The following is a description of a gene set: An abnormality of the external nose. Abnormal external nose morphology Human Gene Set: HP_ABNORMAL_EXTERNAL_NOSE_MORPHOLOGY studied in species Homo sapiens, and this is the list of marker genes: BCR, FLNB, FRMPD4, HDAC4, EFEMP2, MARS2, CDK10, OFD1, LRP4, EDAR, PTPRF, ZIC2, HUWE1, PEPD, RAP1GDS1, H3-3A, CHST14, PRKCZ, PUS1, PACS1, EDARADD, PHGDH, COL3A1, CHD5, GLB1, ALG3, SKIC3, BICRA, NFIX, ASXL1, ABCA12, TRIO, IFT122, ADAMTS18, COG1, CILK1, ANKRD11, PLAAT3, RAC1, ZNF699, TMEM107, ADGRG6, BRF1, TP63 (NCBI Gene Id 8860), PNKP, RHOBTB2, NSD2, WWOX, UFC1, ZPR1, PIGL, ALDH18A1, SRD5A3 (NCBI Gene Id 79644), INPP5E, AP4B1, RALGAPA1, SHANK3, ALDH1A2, DIS3L2, ATP6V1A, GJA1, SALL4, SPTBN1, EYA1 (NCBI Gene Id 2138), GLI3, CRIPTO, PEX11B, HS2ST1, JMJD1C, PDHA1, POU1F1, PTF1A, FZD2, ATP7A (NCBI Gene Id 613259), NALCN, SPEN (NCBI Gene Id 348488), PIGY, TEFM, AGA, H4C3, PGAP2, KCNJ11, NUP85, NODAL, COG8, TXNL4A, DNMT3B, PKHD1, EIF5A, LTBP3, ADAR, SMARCAL1, KDM6A, H4C5, JARID2, TBCE, CUL7, SETBP1, SNX14, CERT1, CAPN15, SYT1, AMMECR1, FOCAD, CHD6, PDE4D, COL27A1, PEX5, STAG2, RALA (NCBI Gene Id 5898), INSR, OTX2, KAT6A, CEP55, MED25, ZMPSTE24, GAD1, SOST, UBE2A, SLC6A9, SLC25A46, HES7, ATN1, FOXP1, DZIP1L, PTCH1, MAN2B1, ATIC, BRAF, CAMTA1, NR2F1, MAPK8IP3, MIPEP, CACNA1B, COL1A2, PYCR2, SUPT16H, PIEZO2, CNOT3, RBBP8, ASNS, CPSF3, AGL, VPS51, HIVEP2, RPS19, ARID1B, NXN, TOPORS, FBXO31, TGFB3, CAPRIN1, MSL3, TWIST2, ATR, TUBGCP4, NKX6-2, DOCK7, TRIM8, PAK3, PARS2, EXOC2 (exocyst complex component 2), TOMM7, SIK1, CEP120, LETM1, CASZ1, GCSH, CRKL, FLII, IER3IP1, RLIM (ring finger protein, LIM domain interacting), SNRPN, GDF11, BUB1, MPLKIP, CLCN3, BCL11A, PIGF, GREB1L, XPC (NCBI Gene Id 7508), FANCL, ROR2, WDR19 (NCBI Gene Id 80203), MED12L, CNTNAP2, TRIP11, AXIN1, HNRNPH1, DDB2, ARID2, IL6ST, MED27, ACTB, RUNX2, TRPV6, TRPS1, APC, FREM1, GH1, TBX2, LUZP1, PPP1R15B, DDR2, KMT2D, FIG4, ACSL4, COG6, FGFR2 (fibroblast growth factor receptor 2), ESCO2, NEXMIF, MYMX, CASK, MGP, MYO18B, COL1A1, B3GALT6, CUL4B (NCBI Gene Id 8450), FRA10AC1, CSGALNACT1, LSM11, KDM3B (NCBI Gene Id 51780), BBS2, HPDL, LMBR1, CDK19, SEC24C, BMP2, RAB3GAP1, TUBGCP6, DLK1, NSUN2, ARL13B, KCNA1, PEX6, MADD, ZFX, METTL5, NUP188, ELN (elastin), HRAS, USB1, RPS6KA3, SETD2, TWIST1, KIF15, MBD5, WASHC4, PIK3CD, FRMD4A, PEX3, COG4 (component of oligomeric golgi complex 4), KDM1A, FBXL4, NF1, FGD1, HK1, SMARCE1, ZNF292, SMARCD1, SCYL2, EDA, GRIN1, ORC4, STIL, SLX4, PRKD1, COLEC11, CD96, AHDC1, PHF8, SLC25A24 (solute carrier family 25 member 24), DLX4, LEMD2, RREB1, CRIPT (CXXC repeat containing interactor of PDZ3 domain, NCBI Gene Id 9419), EXT1, GPC6, LZTR1, GPC3, RPGRIP1, RECQL4, CSF1R, CCNQ, DYRK1A, CPT2, TRAF7, RECQL, NSRP1, ADAT3, PPP1R21, ARMC9, HSPG2, RDH11, MEF2C, CTSK, CEP290 (centrosomal protein 290, NCBI Gene Id 9707), IGF1, RUSC2, MICU1, ADAMTSL2, RBMX, TSPEAR, MAPK1, CLCF1, WDR26, DICER1, ZNF462, BLTP1, RPGRIP1L, DPYD, CCDC8, RIPK4, CEP104, CPLANE1, PPP2R1A, WDR35, KCNN3, CDC42BPB, GP1BB, KDM5B, KDM4B, TAPT1, KIFBP, PGM2L1, MAB21L1, GABRD (gamma-aminobutyric acid type A receptor subunit delta), ADNP, NBN, RMRP, NFIB, ARSL, TMEM53, COL18A1, CEP57, SMC5, STXBP1, TMEM237, TMEM138, IDUA, PAX7, ALX4, SLC29A3, ASH1L, ZBTB20, BANF1 (barrier to autointegration nuclear assembly factor 1), FLCN, BCOR, THUMPD1, BRD4, SPOP, THOC6, CNOT1, SCN2A, PPP2CA, RBM10, PEX16, PRIM1, MYMK, RIPPLY2, FRAS1, QRICH1, TRIP13, SMG8, SPRTN, CLP1, TMEM231 (transmembrane protein 231), OCLN, B9D1 (B9 domain containing 1), AKT1, ALG13 (ALG13 UDP-N-acetylglucosaminyltransferase subunit), SUMF1, FGF20, NOG, IFT56, EP300 (E1A binding protein p300), MAP2K2, PUF60, BMPER, PRKAR1A, ZEB2, RNU7-1, SIM1, PIGP, NACC1, ASXL3, PIGW, CHD2, TMEM94, ESS2, IQSEC2, EFTUD2, PRKACA, FREM2, MCTP2, ALG9, MEG3 (maternally expressed 3), PPP1CB, INTS1, MYT1L, HNRNPR, GPC4, RAD21, IFIH1, TAF4, LMBRD2, CDK13, NEK1, NIPBL (NCBI Gene Id 25836), HNRNPK, FAM20C (NCBI Gene Id 56975), MECP2, TOE1, POLD1, LFNG, DVL1, TMEM70, IL11RA (NCBI Gene Id 3590), ERCC4, EFNB1, MEIS2 (NCBI Gene Id 56908), FGF3, ALX3, TOR1A, ECE1, AHI1, DOCK6, EXTL3, PMM2, ATP6V0A2, KDF1, MTX2, ZNF148, PAM16, ACTL6B, USP9X, SLC2A1, ACTG1, EXT2, SUFU, SETD1A, IFT52, RET, SMOC1, GLI2, SUZ12, TLK2, COL11A1, TCTN1, POGZ, TRRAP (transformation/transcription domain associated protein), FBXO11, PLEC, AIMP2, FOXC1, ATAD3A, EIF4A2, PEX1, VAC14, DDB1, YY1, TGIF1, ALDH6A1, NEDD4L (NEDD4 like E3 ubiquitin protein ligase, NCBI Gene Id 93998), FLNA, MGAT2, SLC37A4, DGCR8, GPAA1, FGFRL1, MESP2, LRPPRC, CHRNA1, KATNB1, ADAMTS3, SLC17A5, PURA, DPF2, FOXP2, ZMYM2, ANTXR1, GMNN, DMXL2, NGLY1, XRCC4, RARB (NCBI Gene Id 5915), ERCC2, CTNNB1, LBR, UBE4B, B9D2, TCF20, SLC4A10, ITCH, ITGA8, FAM149B1, TCF4, PEX12, PAFAH1B1, ASCC3, HYLS1, HOXB1, EBP, ABCC9, MLXIPL, WLS, TRAIP, PPP2R3C, ABCC8, TREX1, BUB3, LIFR, SIX3, ASXL2, FOXH1, AP2M1, CREBBP, MAP3K7, ARX, PDE6D, MAN1B1, NOVA2, SLC6A1, MED12, TRMT10A, CLPB, CDH11, RNU4-2, SEC23A, SMPD4, PTPN11, DOCK3 (NCBI Gene Id 1795), POU4F1, ATP6V1B2, CEP152, TGDS, SLC2A10, RBM8A, DNMT3A, RNF2, SOX5, SIN3A, SNAP29, SMARCA2, CHRNA7, WNT9B, PQBP1, GNAO1, SMARCC2, GRIP1, C2CD3, ESAM, KAT5, HDAC6, PCDHGC4, ARID1A, TRIP12, MVK (mevalonate kinase), MESD, COL11A2, NHEJ1, PEX10, PEX19, KNL1, PLK4, TBCD, IFT74, DLL3, AUTS2, SNIP1, SMARCB1, DNA2, CNOT2, MRAS, PIGN, EBF3, RTL1, KCNJ2, FOXA2, NEUROD2, KMT2A, PRMT7, MPDZ, PEX14, SOX9, PBX1, SATB2, PLCB3, CKAP2L, CDKL5, YWHAE, DLL1, C12orf57, WNT5A (NCBI Gene Id 7474), PIK3R1, TXNDC15, CEP41, RNF125, CC2D2A, MMP23B, CPLX1, NSD1, ATRX, POC1A, LHX4, CSPP1, DYNC1I2, DGCR6, NAA10, MAPKAPK5, AP4M1, ERF, SRRM2, TBCK, MEGF8, PLCH1 (phospholipase C eta 1), FTO, BAP1, PORCN, EDN3 (NCBI Gene Id 1908), TMEM216, EDNRB, HIRA, ATP6V1E1, EXOSC1, SLC32A1, TCTN2, WDR73, EIF2S3, CBY1 (NCBI Gene Id 25776), ARL3, EDEM3, TONSL, DONSON, PUS7, SKI, SH3PXD2B, PIGA, PCNT, PDPN, CHRND, GNS, NRAS, ATRIP, COL2A1 (collagen type II alpha 1 chain), ECEL1, TCTN3, ZNF423, RNASEH2A, RAI1, CTCF, TBX6, SAMHD1, SOX4, PCGF2, NFKBIA, AFF3, WRN, CUX1, PIBF1, TUBGCP2, POLR3A, TBC1D20, PRKAR1B, TBX1, CASP2, EDA2R, SMARCA4, FBXO28, GHR, KIF7, DISP1, NFIA (NCBI Gene Id 4774), HNRNPH2, DVL3, BPTF, PTEN, LAS1L (LAS1 like ribosome biogenesis factor), MYCN (NCBI Gene Id 53360), CCNK, CENPJ, GBA1, EXOSC2, KMT2B, GNPTAB (N-acetylglucosamine-1-phosphate transferase subunits alpha and beta), GAS1, GNPAT (glyceronephosphate O-acyltransferase), UBAP2L, FH, RNU4ATAC, SETD5, NEK9, CRLF1, KCNJ6, CANT1, SIX2, PEX13, PGAP3, PPM1D, KCNK9, INPPL1, MMP2, SPECC1L, SOX3, ZBTB24, TFAP2B, KPTN, LRP2, KANSL1, GATAD2B, MAN2C1, PHF21A (NCBI Gene Id 51317), SMS (NCBI Gene Id 6735), KIF11, KMT5B, IFT43, RPL10, UNC80, PRPS1, DHCR7, SRCAP, IARS2 (NCBI Gene Id 55699), KCTD1, MKS1, DGCR2, CHRNG (NCBI Gene Id 1146), ALX1, GRM7, CENPF (centromere protein F), SMG9, AFF4, NARS2, HDAC8, ACTG2, BRCC3, TAF6, CWC27, TBC1D23, TBL1XR1, MITF, IRX5, KDM5A, FGFR1, LMX1B, KNSTRN, RAC3, RFX7, POR, PSAT1, MBTPS2, PTH1R, MN1, PROP1, PAH, TMCO1, CSNK2A1, ABCA5, POLG2, OBSL1, ERCC5, PYCR1, AFG2A, TMEM218, PLOD3, KATNIP, UBR1, SC5D (NCBI Gene Id 6309), VPS35L, MAFB, PAX1 (paired box 1), GJA5, FBN1, PPP3CA, RNASEH2C, FOXG1, MED13L, PHIP, CENPT, AIFM1, BUB1B, RNF135, FGFR3, SMC1A, XPA, GNAI1, TMEM67, MYH3, RHOA, PIGV, KIAA0586, LMNA, EPG5, AP4E1, SET, CDC42 (NCBI Gene Id 998), FMR1, IL2RA (NCBI Gene Id 3559), KLHL15, GJA8, SCNM1, FILIP1, EHMT1, POLRMT (RNA polymerase mitochondrial), DDX3X, RAB3GAP2, ODC1, SCN1A, SLC26A2, METTL23, CCDC22, UFD1, ZC4H2, NOTCH2, CTBP1, GFRA1, PEX2, CLIC2, KIF14, PIK3C2A, PIGO, PIGQ, PEX26, KCNJ8, ZNHIT3, ANKRD17, RAB23, CAV1 (NCBI Gene Id 857), TOGARAM1, GLUL, B3GLCT, CHMP1A, CBL, HESX1, POLR1A, SHOC2, HECW2, COMT, CIT, XYLT1, ZMIZ1, KIAA0753, CENPE, JAG1, NPHP1, RIC1, NANS, ADSL, RNASEH2B, CEP295, ERCC3, WDR4, LONP1, MUSK, LIG4, DEAF1, VPS13B, IGF1R, BRCA1, PUM1, KCNAB2, PRDM16, HIC1, SLC35C1, WAC, SCAF4, TFAP2A, SLC25A22, ZSWIM6, TRAF6, PDGFRB, TAF1, TRPM3, CHN1, PRKACB, KCNE5, MID1, ARVCF, STAT5B, AP4S1, CCDC47, FGF8, RAB18, RYR1, SMC3, TBX4, TBC1D24, PIGT, SOX11, DHX37, WDR62, CDON, KCNJ5, MAP2K1, H3-3B, BMP4, RERE (arginine-glutamic acid dipeptide repeats), ASPH, SHH, KAT6B, SOX10, FLI1, FBXL3, SYNGAP1, PAICS, HSPA9, SCARF2 (NCBI Gene Id 91179), AGO1, AASS (NCBI Gene Id 10157), KRAS, RAP1B, KCNH1, UBE3B (NCBI Gene Id 89910), TPR, PAX3, TMLHE, LTBP1, SCN1B, DHCR24